The following is a description of a gene set: RUNX3 regulates NOTCH signaling studied in species Homo sapiens Human Gene Set: REACTOME_RUNX3_REGULATES_NOTCH_SIGNALING, and this is the list of marker genes: KAT2B, RBPJ, NOTCH1, MAML1, MAMLD1 (NCBI Gene Id 653998), CREBBP, EP300, JAG1, MAML2, KAT2A (lysine acetyltransferase 2A), HES1, MAML3, SNW1, RUNX3